Given this list of marker genes GPR137C, PIGA, ALCAM, TGFB2, MTMR14, ZDHHC7, LRRC41, NR2C2AP, TMEM63B, IL15, SLC26A4 (NCBI Gene Id 5172), LMTK2, FXR1, MAFB, YWHAB, NOG, TRIM59, WNT1, ADAMTS15, NPTN, PDE1C, ATG14, UBE2D3, MAP3K4, TMEM54, SSR1, ADAM23 (NCBI Gene Id 8745), NOL4, RAB34, SESN2, MMP10, PIGS, VMP1, PRKCZ, NCOA1, ARRDC3, KCTD16, ATXN1, CAMSAP2, AGO4, SESN3, SBF2, ZDHHC23, BTBD3, RPS6KA5, UBE4B, PITPNM2, CASZ1, ITSN2, MMP15, TMEM9B, NAT14, DUSP1, DYRK2, NCKIPSD, OSBPL11, TEK, RALBP1, SGCB, RBM24, TMEM170A, C1GALT1, JMY, SYNJ1, ZNF804A, WDR20, STARD13, KLF5, BTAF1, KDM7A, ROBO1, KIAA0232, PPP1R9B, KRT76, S1PR1, F3 (NCBI Gene Id 99486), ARHGEF12, CEP55, SIK1, CDC14A, ADAM22, MOSPD1, CYB5R4, CD72 (CD72 molecule), RAB14, CNTNAP3B, CDKL5, ABCD3, TOMM70, RICTOR, KLF4, DNMT1, GRID2, ACVR1, CDH20, WDFY4, PRKAA1, SLC25A44, ATP6AP2, ABCA1, SIRT7, SZRD1, ARK2N, RANGAP1, OTUD4, ZDHHC17, PHF20, GMFB, GPATCH8, USP31, WNT10B, TGOLN2, LDLR, TRAK2, TBL1XR1, ZBTB18, ITGB8, AGO1, FBN1, USP33, MMP13, GLRX5, ATP11A, ATP8A1, B4GALT5, FAM234A, MRAS, LRP2, CSF1, PGRMC2, CBLL1, MAP2K1, ADGRF5, SNX27, ADCY2, MTMR10, EPAS1, FEZ2, PTGES3, KIAA1217, ROBO2 (roundabout guidance receptor 2), ENSG00000275993, ESRRG, TENT2, CCDC141, HOXC8, SMS, NEURL4, PEAK1, FAM168B, STOX2, CADM1, MAFG, CS, MITF, NHS, INO80, KAT7, UBAP2L, XPO4 (exportin 4), EYA3, SNN, SLC16A6, GTF2H1, ITGA9, CDK19, FMR1, HECW2, EPN2, ERBB3, ADAM10, CERS6, ARFIP1, TNRC6A, DOCK6, AGFG1, NME7, HOMER1, EPM2A, VCF1, CAND1, ADAMTS19, NRARP, ESR1, FOXF1, ABCB7, BACH2, ARHGAP21, ZFYVE26, SKIDA1, WDR47, RNF38, CABP7, HBS1L, ADGRB3, CBLB, PPP1R10, MDFIC, TGFA, GPCPD1, ARL6IP1, CANX, JARID2, EPS15, TXNIP, GADD45A, DMXL1, SOS2, EOGT, AP4E1, PRKAG2, ATXN7L1, CDK5R1, INHBB, SCN9A, SLC2A1, ITPK1, MEOX2, RMND5A, RGMA, MNT, CTSA, ING2, NPTX1, LEPROTL1, SLC24A3 (NCBI Gene Id 96617), CCKBR, GAP43, ADAM17, DICER1, LIPA, TMEM266, MLLT10, GPRC5A, MAP3K9, KRTAP2-3, RTN4, MRGPRX3, USP32, VPS37A, MXD1, PPP6R1, MACIR, CDS1, NFAT5, ZCCHC2, ARL8B, FAM161A, UHMK1, ROCK1, USP48, PLAA, LBR, BTBD10, MGAT4A, LTBP1, CELSR1, SESTD1, BCL2L11, RASSF8, PIK3C2A, PRNP, CYTH3, TANC1, SIX4, KIF14, ELAVL2, PHF3, ELAVL4, B4GALT6, EFNB2, KLF6, DENND4C, ANXA4, SRSF11, PNPLA6, CLTA, PHACTR2, RUNX2, NPEPL1, NOL4L, PRICKLE2, CFL2, ERRFI1, YTHDC2, ATP4B, CHD7, GPM6A, DCP2, CCDC6, TGIF2, MED12L, MMD, MACROH2A1, AHDC1 (NCBI Gene Id 27245), COL4A1, ITGA5 (NCBI Gene Id 3678, integrin subunit alpha 5), TBC1D8, SPTY2D1, SNAP91, BICC1, NT5C3A, CDKN1B, A4GNT, QKI, BMP3, SECISBP2L, ARF4, ZNF821, FAM43A, DLG2, MPL, CUL5, CHUK, POU3F2, RFX7, ATP2B4, CNTN4 (contactin 4), DDX6, MTMR9, IGFBP5, RC3H1, BAZ2B, E2F7, AKAP1, UCP3, ANGEL2, KMT2A, CLCN6, TNRC6C, MLLT6, CIITA, CCT6A, VSIG1, MTCL1, MIER1, LYSMD2, NRP1, TMED7, OBI1, here is a description of the gene set: from publication Chen Y, Wang X (PMID 31504780) studied in species Homo sapiens Human Gene Set: MIR148A_3P Genes predicted to be targets of miRBase v22 microRNA hsa-miR-148a-3p in miRDB v6.0 with MirTarget v4 prediction scores > 80 (high confidence targets).